The following is a description of a gene set: studied in species Homo sapiens Genes predicted to be targets of miRBase v22 microRNA hsa-miR-6732-5p in miRDB v6.0 with MirTarget v4 prediction scores > 80 (high confidence targets). Human Gene Set: MIR6732_5P from publication Chen Y, Wang X (PMID 31504780), and this is the list of marker genes: HJV, SLC25A27, STX17, DBF4, CAPN3, SLC1A3, JADE1, DYNC1LI1, RAB27A, ARRDC4, NAV1, CIC, SKI, TMEM169, MARF1, GPD1L, LATS1, OAS2, LAPTM5, RND1, IDUA, ZNF580, FOXP4, ABCC5, SH3PXD2A, KLK3, WDFY1